Given this list of marker genes SLMAP, CA7, TBC1D22A, CHGA, SPOCK2, KCNJ10, ZNF512B, TBC1D13, TNS3, DEDD2, GPM6A, THNSL2, BMF, NHLRC3, RNF135, POU2F2, INTS6, SEZ6L2, PPARGC1A, SLC8A3, SYT9, FAM53A, MIEF2, OTUD7A, SNTB2, TRIM7, PHF8, PPP6R3, OLFML2A (olfactomedin like 2A), GRB10 (growth factor receptor bound protein 10), SLC35B1, VRK3, DEXI, BIK, SDR16C5, LRRC20 (leucine rich repeat containing 20), OXLD1, HAPLN4, REPIN1, ZNF704, RPL13, VDR, RAB5B, RAPGEF5, MVB12B, PITPNM3, ISM2, TMEM239, DENND4B, SLC23A3, CADM3, CDH24, VPS39, KLHDC8A (NCBI Gene Id 55220), WNT9B, CCNY, PACS2, NTN1, PPP2R5D, NDOR1, GRM4, CYTH1, NDUFA2, LRRC8E, ABAT, ORAI2, RPL41, DDB1, SLC43A2, SPICE1, TMOD2, NEURL1, PTPN12, PSMD9, VPS37D, B3GNT7 (UDP-GlcNAc:betaGal beta-1,3-N-acetylglucosaminyltransferase 7), MS4A7, ERF (ETS2 repressor factor), AP5B1, SBK1, ADAMTS6, FLRT1, CPEB3, FKBP5, GAS7, NAGS, CSF1, TTYH3, SUSD5, RXRG, TRARG1, ABLIM3, PLEKHA6, PPP3CB, UACA, ZER1, SORCS2, GSTZ1, ATP2B1, ACTR1A, PSMA3, USP42, SEZ6, EEIG1, MTCL2, CHAC1, NOTCH2, WDTC1, NPLOC4, IL1RN, USP2, CST9, DAB2IP (NCBI Gene Id 84635), PNMA8B, APH1A, SPNS2, BOLA1, MEGF11, SLC6A17, ASB8, SERF2, GIMAP1, MICOS10, here is a description of the gene set: species: Homo sapiens Genes predicted to be targets of miRBase v22 microRNA hsa-miR-6837-5p in miRDB v6.0 with MirTarget v4 prediction scores > 80 (high confidence targets). from publication Chen Y, Wang X (PMID 31504780) Human Gene Set: MIR6837_5P